Given this list of marker genes TPBG, FAM118A, SLC4A7, VGLL3 (NCBI Gene Id 51159), PHF8, GON7, SVBP, NLK, FNDC3A, RRAGB, TMTC3, SCGN, GPC5, PTK2B, GRIA3, RNF185 (NCBI Gene Id 91445), FAM131B, TCF21, SERTM1, IMPA1, APOBEC4, RAN, MTHFD2, NKRF, COLEC10, PDE4B, PMEPA1, ASXL3, BMPR2, VEZF1, KRIT1, RBMS3, IRS1, RORA, TMEM170B, IGSF1, CLMP, UTP11, ANXA4, HSPD1, COX18, NPAT, FNBP1L (NCBI Gene Id 54874), ANKRD34B, AKAP5, KHSRP, IL5, KIR2DL1, MSR1, PAPOLA (NCBI Gene Id 84718), TMEM123, POU3F2, ZFP90, EBF3, CABYR, WDR17, PLEKHA3, APLP2, OSGIN2, PNO1, UNK, FGF9, CYB5B (NCBI Gene Id 80777), OPRM1, ERMN, EPG5, SAMD12, SIRT1, TMC7, STXBP5, TESMIN, ZNF280C, NXPH3, CLEC3A, AZI2, ADPRM, CPEB2, DUSP1, TIFA, PPARGC1A, SPAG8, RAVER2, ADGRB3, NEBL, TLE4, SVEP1, NOP58, SRP54, COL3A1, HNRNPR, DNAAF9, FEM1C, PREPL, CAPS2, TTN, EIF5A2, TMPRSS13, TM7SF3, RUNX2, TPR, FOXK1, USF3, ALDH5A1, IFIT5, MTMR6, TRPC6, RANBP3L, CCL28, FBXO9, SAMD13, SNAP47, CNTLN, CTSV, RBM47, ADM, TJP1, PTPRG (protein tyrosine phosphatase receptor type G), SDHAF4, MPDZ, RPF2, UBE2G1, TNRC6B, SEPTIN14, SAT1, CCR3, PLCXD3, BACH1, PLN, NDFIP2, THBS4, C4orf46, ZNF711, GMNN, MDGA2, HTR1D, WDR47, FBN2, PTPN4, OIP5, HRH4, SYT4, ARL15, ZNF326 (zinc finger protein 326), NPR3, NR2C1, AQP4, FOXE1, RGS18, BMPR1A, SDR9C7, PDSS2, RCBTB1, CGRRF1, DSTYK, here is a description of the gene set: from publication Chen Y, Wang X (PMID 31504780) Genes predicted to be targets of miRBase v22 microRNA hsa-miR-4670-3p in miRDB v6.0 with MirTarget v4 prediction scores > 80 (high confidence targets). studied in species Homo sapiens Human Gene Set: MIR4670_3P